Given this list of marker genes HNRNPA3, TIMP2, NCBP2, GOT2, HNRNPC, TIGD7, SNHG26, HEATR1, SSBP4, SETD4, NUFIP1, SLC17A9, SRRT, GLRX5 (glutaredoxin 5), TMEM201, NUP214, SLC37A4, TSPOAP1, METTL26, LPCAT2, NOL10, ISG20L2, HSPB1, ZNF530, TMEM116, ADISSP, C11orf21, ZAR1, DHCR24, SLC25A32, TELO2, GPD1L, ARMC10, CETN2, RRP1, LYST, TRIM14 (NCBI Gene Id 9830), LBHD1, TRG-AS1, HMGB1P4, POLR2E (NCBI Gene Id 5434), ZNHIT2, CDC42EP4, MGAT4A, PSMA5, RBM25, HDDC2, TTLL12, RBM26, HIVEP2, MRPS26 (mitochondrial ribosomal protein S26), MIR570, HSPH1, C7orf50, KNOP1, POLR3G, DLEU2, BNIP3L, MINDY2, BDP1, ECI2, MRPL16, SCFD2, NCF1, SMIM30, RBM28, CD302, SCD, PRXL2B, CALR, PRADC1, ACOT7, GFM1, TUBB2A, ERGIC1, HSPA1B, DDX19A, NUDT4, ASAH1, SAR1B, ISCA1, IGSF10, RNGTT, BAG1, DNAAF5, ARHGEF40, PEBP1, PTMA, SYNCRIP, COPS7B, SPART, ABCF2, PDCD11, B4GAT1, DDX10, MARCKS, MICOS13, TREX2, BAZ2A, SSB (NCBI Gene Id 6741), FOXRED2, ELP1, HNRNPA3P17, MPZL1, PALS1, SSBP3, CLEC11A, ADAT2, ARHGAP25, ASXL1, TRMU, BAHCC1, PPP1R14B, OXER1, TOMM22, EIF4E (eukaryotic translation initiation factor 4E), SLFNL1, B3GAT3, ZNF667, COPRS, AGPS, GEMIN4, CFL2, AMD1, STK33, RANGAP1, B4GALT5, NUB1, TOR1AIP2, RRS1, PPP2R5D, ATP23, BTBD7, HNRNPD-DT, ZDHHC11, SNHG16, GBA1, CCDC85B, RALGAPA2, DCBLD2, EBF3, TFRC, TOMM5, HSP90B1, ANAPC5, FAM118B, DYRK2 (NCBI Gene Id 8445), SANBR, COX16, ARHGDIG, TAF5L, L3MBTL2, TGIF2, LYAR, FAM111A-DT, MANEA, KANK1, PDE4A, EIF4E2, PPAN, EEF2K, DR1, SNHG4, POLR3H, SCO2, SFPQ, RIOX2, WDR45, TOP1MT, AIF1, SRM, PHB1, VDAC1, PSME3, GNL3L, RBM12, DHRS9, MYB, DTD2, NLN, DCTPP1, IL18R1, RPGRIP1L, IFT56, IMP4, IFT57, MSI2, CENPW, EWSR1, GRPEL1, ACADSB (NCBI Gene Id 654185), TMED4, RDH13, SLC25A30, GEMIN6 (NCBI Gene Id 79833), DLX4, DKC1, TSR3, FABP5, WDR35, MTURN, EEIG2, ARHGAP9, NOP16, COX7B, CHMP1A, TRMT10C, ITGA4, ATG3, SLC43A3, NHP2, MLC1, NUDT12, FXN, IPO4, RPS26, L3HYPDH, EHD1, TIMM17A, GUSBP1, MRI1, XPO5, HILPDA, DNAJB1, TEX261, COPS9 (COP9 signalosome subunit 9), ALDH5A1, SEPTIN7, WT1, FKBP1A, MAZ, MRPL14, DNAJA1, TOMM6, FASN, UBA2, SFN, LUC7L3, TMEM177, DANCR, TMEM50B, POP7, PRCP, MMACHC, GLA, CENPV, SKP2, AURKAIP1, LYRM2, CYB5RL, VKORC1L1, SLIRP, PRKACA, HSPA4L, EIF3B, PRR5, MCM8, RHOT2, TBL3, TIMM8B, NAA38, BIN2, ZBTB16, NR2F2, ADAM15, DNAAF3, DNAJB6, FAM229B, DHX57, SACS, RRP9, ZFP36L2, ZMYND19, SERF2, BDH1, MT1X, CHST7 (carbohydrate sulfotransferase 7), TNFSF13B, CHCHD7, CKS2, FLVCR1, SLA, CLTB, NUP62, P2RY8, PRKCQ-AS1, MS4A3, HS3ST3B1, AQR, NANOS1, SRGN, DEPDC7, MRPL21, RAD18, WDR90, SRSF11, PPP4R3B, CD81, DDX31, MRPL23, GADD45GIP1, ERAP2, SNRPA1, GNB4, FKBP4, ACTR5, RRP15, MAD2L1, FBRSL1, NEFH, PLA2G4A, SLC19A2, RRP7A, WDR4, ARRB1, MOB3C, SLC5A6, HDAC2, PRKAR2B, AZU1, PCCA-DT, MRPL57, DIXDC1, CHML, NUDT7, SCLY, SLC25A12, ANKRD27, IFI16, ZNF618, MON1A, SDF2L1, IRX3, NFE2L3, TBC1D4, CCDC124, GALNT2, VAMP8, LARP4, ZBTB24, TWNK, SOD2, TET1, PHACTR1, DUSP23, WDR74, FGD3, JPT1, RFTN1, SCAMP1, SEH1L, CEBPA, RPS6KA4, TMEM120B, RET, GNL3, TGS1, KLHL18, CEP43, PPP2R2D, ATP5ME, FRG1HP, UBAP2L, SCARB1, POP1 (POP1 homolog, ribonuclease P/MRP subunit), LRG1, DIMT1, TXNDC17, SNHG12, SQSTM1, S100A11P1, RRP12, FARSA, CENPM, UBIAD1, CRELD1, PLD6, MORN2, VKORC1, POLR2D, PES1, DPYSL2, METTL8, ECE2, PM20D2, TNFRSF1B, WDR77, FGFBP3, SYNGR2, TMIGD3, ANTXR2, RSC1A1, NAXE, YY1, SFXN4 (sideroflexin 4), MRPS12, MRPL41, SNHG5, NRROS, RBKS, IGFBP7, COX11, PPIH, MRPS34, ACP3, NCOA1, UPK3A, SNRPF, POLR1G, ST20-AS1, DBR1, GNPNAT1, MORF4L2, DCAF8, MAP2K3, PRTN3, POLR2H, GPS2, ZSCAN31, SLC25A10, TUBGCP4, DPP7, KPNA5, NAGPA, H2BC7, MTCH2, ALG1, RDH10, TPM3, DHX33, MRPS25, PAK1IP1, TFDP1, PNO1, DOHH, SEC62, PMPCA, NAA20, SLC25A39, SNRNP70, TENT5A, BCCIP, C4orf33, UQCC3, RAD1, STIP1, RNASE2CP, CYB561, YBX3, ZSCAN5A, ZNF816, MIF, DNAAF2, RPL27A, HNRNPD, C4orf3, CA2, GALNT14, NOL6, PSMA2, GPATCH4, RIDA (NCBI Gene Id 137671), NTHL1, CHI3L1, RHOF, PNP, DHX37, ABCE1, CCND1, TGFBRAP1, MRPS17, ILF3, PTGER2, ATP5MC3, NDUFAF8, ATF7IP2, SPRYD4, APOOL, INF2, TIMM21, LGALS14, TIMM13, RFK, CHST4, C1QBP, AHSA1, ALG3, AKT2, RMND5B, TP53I13, SLAMF8, IPO7, ELOF1, IKZF1, MGLL, PACRGL, TXLNG, ELP2, DLEU1, IMP3, LTV1, NME4, STOM, MOGS, HIVEP3, UNC93B1 (NCBI Gene Id 81622), CABLES1, THAP4, STING1, SORL1, CHORDC1, LAPTM4B, NDUFS3, LGALS12, RITA1, SPTLC2, TRNP1, GRWD1, FUBP1, IDH3B, PALS2, BOLA3, TMEM97, LSM7, SLC7A6, DFFB, PISD, PRPF31, MROH1, LGALS9, ALYREF, SFXN1, TWIST1, HSPD1, PGK1, LSP1, HK2-DT, DUS3L (dihydrouridine synthase 3 like), MTFMT, NPRL2, PHACTR3, MRPS30, MICAL2, MYLIP, EIF5B, PPARGC1B, TFAM, B3GNT7, MRPS23, PDAP1, EEF1AKMT4, KBTBD6, NDUFS5, SUMO1, DHCR7, NAA25, NHP2P2, ARL5A, EBPL, DNAJB9, ATP11B, PSMC2, NOL11, P2RY6, SLC39A4, HNRNPDL, COQ3, THADA, ENAH, ANKRD36, RANBP1, LAS1L, POLD2, CA8, GRAMD4, TSR1, PIAS2, PWP1, MRPL36, CWF19L1, VARS1, COL4A2, ADORA2A, WDR36, RGS14, IKBIP, SLC40A1, DCAF13, PFDN6, NCR3LG1, EBP, GM2A, RNF207, CWC25, PLAAT1, CCT3, NXPE3, TENT5C, PRMT2, PEX5, RFESD, SLC2A5, OVAAL (NCBI Gene Id 148756), DACH1 (NCBI Gene Id 1602), UTP23, ZNRF3, EXOSC7, GADD45B, SPR, ZNF593, FARP2 (NCBI Gene Id 9855), TRAPPC2L, ATP5MC1, TMEM109, TBC1D1, NDUFA11, IL6R, FOXF2, MCAT, CFAP73, TIMM23, NSD3, FAM210A, HSP90AA1 (heat shock protein 90 alpha family class A member 1), FAM200C, HMGN3, EARS2, APBB2, PRMT5, ZNF74, NUP155, EI24, LRP3, CYB5A, MANSC1, DPCD, TNFAIP2, DUSP3, TJP2, RNASET2, ASB13, MACROH2A1, TRMT10A, GCAT, DUSP4, SLC29A1, HDAC4, MRPL12, STRBP, CLPTM1L, CLUH, PRPS1, GAS5, RCC1, MATK, FSCN1, MPHOSPH6, PTPRC (NCBI Gene Id 5788), UAP1, POLR2F, SLC11A2, GEMIN5, PSMG4, POLR1C, MRPL4, PIGW, TARDBP, ACSL5, PHLDA2, MTHFD2L, DEAF1, NUDC, ADRB2, CYB5D1, SRFBP1, RPL21P68, PCOLCE2, ERCC2, PRDX4, METTL21A (NCBI Gene Id 151194), TXNL4A, DNAJA4, ALKBH2, EHBP1L1, NIFK, NAA10, PEMT, WDR12, TIMM10 (NCBI Gene Id 26519), SLC29A2, GOLM1, TIMM22, SLC2A1, FAM162A, GAR1, ROPN1L, CCDC26, NDUFC1, FAM98A, MLKL, FCGR1A, GRSF1, C9orf78, EBNA1BP2, INSIG1, ALDH1B1, DNAJC11, RPIA, BID, EXOSC3, ZNF641, TMEM147, IDS, LRRC34, CIAPIN1, ENDOG, CORO7, DCXR, ZNF671, MIR3682, NRGN, DDX18, DCAF4, MED4, EPC2, NREP, PA2G4, DCUN1D5, LPCAT1, LUC7L, N6AMT1, RCSD1, QDPR, NOCT, ANTKMT, MRPL24, SNRNP25, AKAP1, SERBP1, CLPTM1, SORD, SMYD2, UMPS, CUTC, STK11, COIL, SMC4, ZNF574, TMEM70, NASP, ATAD3A, RRP1B, CFAP263, GSPT1, IDH3A, KLHL23, NUDT5, MAPKAPK5-AS1 (MAPKAPK5 antisense RNA 1), NDUFB10, P2RY2, LY6E, RUVBL1, TMEM150C, B3GALNT2, DUT, TPP2, SESN3, ZNF692, ALDH18A1, MRPL44, TRIAP1, CARNMT1, ATAD3B, TMEM64, FJX1, GCSH, GJA3, CAPG, UCK2, FAM201A, CCDC86, PDCD5, ATG7, ESF1, ABCD3, DZIP3, SOX4 (NCBI Gene Id 6659), PGM3, PWWP3A, ZNF486, GTF2H2, TCOF1, GOLGA8N, FAM117B, FCER1G, PRR7, BMP8B (bone morphogenetic protein 8b), GLYR1, UBE2NL, LRPPRC, SHFL, NUP35, PPP1R27, RABL2B, MSH6, IFITM2, CTSG, PTMAP3, NCL, EXOSC4, HS3ST3A1, ETFA, SLC16A1, ATP5MF, AGMAT (agmatinase (putative)), PUS7, POLR1A, NOP2, NOLC1, ME2, GPR85, MREG, MPI, FUT4, UBASH3B, CTRL, FAM136A, NUP88, SDC2, GPR183, ARHGDIA, BZW1, KITLG (NCBI Gene Id 780897), POLR1B, MTFP1, TM7SF3, JPT2, KCTD12, TTC5, WDR46, RNF126, TMEM68, TBC1D22A-DT, CCDC138, SEC11C, SLC25A19, SEMA4B, UBL5, LLPH, KIF20B, PSMA7, DDIAS, LINC00294, ADI1, EEF1AKMT1, GGA2, MRTO4, BOLA2, ANKLE1, SCRIB, MDFIC, SENP3, DDX24, MYO10, PAFAH1B2, NOC2L, SQLE, NELFCD, EMC8, SERF1A, COA7, RLIG1, IPMK, NINJ1, NDUFB7, HPDL, PRPS2, TFB2M, TMF1, DEF8, PTGES2, HSPBP1 (NCBI Gene Id 29987), DHODH (dihydroorotate dehydrogenase (quinone)), WDR3, DHX30, AK4 (NCBI Gene Id 387851), SLC39A10, NOPCHAP1, DDX54, PFAS, SLC19A1, HMGB1, BEND3 (NCBI Gene Id 57673), CBX5, COX5A, PALM2AKAP2, SNHG14, HES6, TNPO2, UNC13B, PRDX1, RPL12P11, SNU13, MLLT6, ANKS6, AP4B1, CEACAM6, CD59, HSPE1, LDHA, EIF3J, MYC, MYBBP1A, PTMAP4, COPB2, HDGF, SLC35G1, PRAM1 (NCBI Gene Id 84106), TRAF3IP3, DRAM1, RNASE3, HMOX2, METTL16, NIP7, TNFAIP8L2, IL17D, MED24 (NCBI Gene Id 9862), FAM111A, CENPX, CFAP97, SIVA1, PSEN2, G3BP1, BZW2, TRIP13, FLT3, SYNGR1, MFNG, CREB3L2, CFDP1 (craniofacial development protein 1), TCF3, LDLRAD3, DDI2, RBBP6, ALMS1, TASP1, HDHD5, KLHL42, here is a description of the gene set: CHR-2797 is a novel metalloenzyme inhibitor that is converted into a pharmacologically active acid product (CHR-79888) inside cells. CHR-79888 is a potent inhibitor of a number of intracellular aminopeptidases, including leucine aminopeptidase. CHR-2797 exerts antiproliferative effects against a range of tumor cell lines in vitro and in vivo and shows selectivity for transformed over nontransformed cells. Its antiproliferative effects are at least 300 times more potent than the prototypical aminopeptidase inhibitor, bestatin. However, the mechanism by which inhibition of these enzymes leads to proliferative changes is not understood. Gene expression microarrays were used to profile changes in mRNA expression levels in the human promyelocytic leukemia cell line HL-60 treated with CHR-2797. This analysis showed that CHR-2797 treatment induced a transcriptional response indicative of amino acid depletion, the amino acid deprivation response, which involves up-regulation of amino acid synthetic genes, transporters, and tRNA synthetases. These changes were confirmed in other leukemic cell lines sensitive to the antiproliferative effects of CHR-2797. Furthermore, CHR-2797 treatment inhibited phosphorylation of mTOR substrates and reduced protein synthesis in HL-60 cells, both also indicative of amino acid depletion. Treatment with CHR-2797 led to an increase in the concentration of intracellular small peptides, the substrates of aminopeptidases. It is suggested that aminopeptidase inhibitors, such as CHR-2797 and bestatin, deplete sensitive tumor cells of amino acids by blocking protein recycling, and this generates an antiproliferative effect. CHR-2797 is orally bioavailable and currently undergoing phase II clinical investigation in the treatment of myeloid leukemia. Genes down-regulated in HL-60 cells (acute promyelocytic leukemia, APL) after treatment with the aminopeptidase inhibitor tosedostat (CHR-2797) for 6 h. species: Homo sapiens Human Gene Set: KRIGE_RESPONSE_TO_TOSEDOSTAT_6HR_DN from publication Krige D, Needham LA, Bawden LJ, Flores N, Farmer H, Miles LE, Stone E, Callaghan J, Chandler S, Clark VL, Kirwin-Jones P, Legris V, Owen J, Patel T, Wood S, Box G, Laber D, Odedra R, Wright A, Wood LM, Eccles SA, Bone EA, Ayscough A, Drummond AH (PMID 18701491)